The following is a description of a gene set: species: Homo sapiens Piezogenic pedal papules Human Gene Set: HP_PIEZOGENIC_PEDAL_PAPULES Flesh-colored or yellowish papules, 2 mm or larger, that are responses to internal mechanical pressure and weakness in the connective tissue in the dermis, appear commonly over the medial aspect of the heel, but in some cases on the wrists. They are thought to represent herniations of adipose tissue through the plantar fascia retinaculum., and this is the list of marker genes: COL1A1, COL5A1, THBS2, AEBP1, COL5A2